Given this list of marker genes CXCL12 (C-X-C motif chemokine ligand 12), PTGIS, VCAM1, FGL2, CXCR4, MYOC (myocilin), BCHE, MEOX2, ADGRL2, ABCG1, KIT, ANO1, CA2, HAND1, GDF10 (growth differentiation factor 10), PIP5K1B, CHODL, ALDH1A2, CST1, SRGN, here is a description of the gene set: studied in species Homo sapiens from publication Mahadevan D, Cooke L, Riley C, Swart R, Simons B, Della Croce K, Wisner L, Iorio M, Shakalya K, Garewal H, Nagle R, Bearss D (PMID 17325667) Top genes down-regulated in the GIST (gastrointestinal stromal tumor) cell line resistant to imatinib compared to the parental cell line sensitive to the drug. Human Gene Set: MAHADEVAN_IMATINIB_RESISTANCE_DN KIT or alpha-platelet-derived growth factor receptor (alpha-PDGFR) activating mutations are the pathogenic mechanisms that characterize gastrointestinal stromal tumors (GIST). Despite excellent responses to imatinib mesylate (IM), patients are relapsing. We developed an IM-resistant GIST cell line (GIST-R) from the IM-sensitive GIST882 cell line (GIST-S) by growing these cells in IM. Gene expression profiling (GEP) of GIST-S, GIST-R cells and two IM resistant GIST patients demonstrated that KIT is downregulated implying a major role in IM resistance. Instead, GIST-R cells have acquired IM resistance by overexpressing the oncogenic receptor tyrosine kinase - AXL - in a 'kinase switch'. Further, the two IM resistant GIST patients express AXL and not c-Kit, seen by immunohistochemistry (IHC). Real time reverse transcriptase-polymerase chain reaction and Western blotting of the GIST-S and GIST-R cells confirmed the switch from Kit to AXL. In GIST-R, AXL is tyrosine phosphorylated and its ligand growth-arrest-specific gene 6 is overexpressed implying autocrine activation. The kinase switch is associated with a morphological change from spindle to epithelioid. Molecular modeling of the kinase domain of mutant c-Kit (V654A) and AXL showed no binding to IM but efficient binding to MP470, a novel c-Kit/AXL kinase inhibitor. MP470 synergizes with docetaxel (taxotere) and is cytotoxic to GIST cells.